Given this list of marker genes Psmc2, H4c18, Dnttip1, H2bc15, H2ac10, Stt3a, H3c4, Psmc5, Psmd13, Psma2, Tmem258, H2ac11, H2bc9, H2ac8 (H2A clustered histone 8), Ganab, Adam19, H2ac4 (NCBI Gene Id 319172), Zmym2, H2bc27, Smarca4, H2ac22, H2bc8, Angptl4, H4c9, Dnm2, H4c1, Psmc1, Psmb6, Pomt2, H4c11, H2ac24 (NCBI Gene Id 319171), H3f3a, H2ac13, Spcs1, Actg2, H2bc1, Dad1, Psmd6, Rbbp7, H3c1, H4c4, Kdm1a, Ezh2, Ost4, Pip5k1c, Psmb4, H3c7 (H3 clustered histone 7), Sec11c, Fyn, H3c10, Mtbp, H2ac19, H4c8, H3c15, Rps27a, Pomt1, Psma5, Psma4, H4c17, H2ac20, H2bc13, H2ac15, Psma6, Psmc6, Cbll1, H2ac6 (H2A clustered histone 6), Spcs2, Rack1, H2bc11, Psma1, Jup, H3c2, Psmb7, Psmc4, Psmd7 (NCBI Gene Id 17463), H4c14, Ddost, H2ac12, H2bc12, Ctss, H2bc22, Banp, H3c11, Psmd12, Twist1, Spcs3, Psmb5, Psma3, Psmc3, H3c8, Prkcsh, Psma7, H2bc7, Csnk2b, Pcsk7, Acta1, Actc1, Cdh1, H2bc3, H4c3, H2ac23, H2ac1, Ctnnb1, H3c3, Ubb, H3c13, Ilf3, H2ac7 (NCBI Gene Id 319165), H4c2, H2ax, H4c6, H3c6, Psmd1, H2az2, H4c12, Rbbp4, here is a description of the gene set: This event has been computationally inferred from an event that has been demonstrated in another species.<p>The inference is based on the homology mapping from PANTHER. Briefly, reactions for which all involved PhysicalEntities (in input, output and catalyst) have a mapped orthologue/paralogue (for complexes at least 75% of components must have a mapping) are inferred to the other species. Reactome Pathway: Regulation of Homotypic Cell-Cell Adhesion part of: Adherens junctions interactions electronically inferred by orthology from the curated human pathway species: Mus musculus